The following is a description of a gene set: species: Homo sapiens A cell cycle process that results in the division of the cytoplasm of a cell after mitosis, resulting in the separation of the original cell into two daughter cells. Human Gene Set: GOBP_MITOTIC_CYTOKINESIS, and this is the list of marker genes: ANKRD53, ARF6, ZFYVE26, CHMP3, EXOC7, IQGAP2, CHMP1B, BBS4, INCENP, ARF1, SON, RAB11A, MYH14, MITD1, RHOC, KIF4A, RTKN, PLK1, SPTBN1, EXOC2, ECT2, ARL3, CHMP2B, MTMR3, ANK3, ESPL1, TRIM36, EXOC1, RHOB, IQGAP3, EFHC1, UNC119, EXOC8, KIF23, VPS4B, RHOA, CUL7, STMN1, PDCD6IP, CDCA8, USP8, CHMP4C, ROCK1, SPAST, EXOC6B, KLHDC8B, KIF4B, NUP62 (nucleoporin 62), CHMP4BP1, APC (APC regulator of WNT signaling pathway), LZTS2, KIF20B, CENPA, AURKB, JTB, CHMP1A, RAB11FIP3, ZFYVE19, MAP9, ANLN, CHMP2A, CHMP6, CHMP5 (charged multivesicular body protein 5), KIF20A, POLDIP2, IQGAP1, SEPTIN6, EXOC6, CEP55, CKAP2, SNX9, CFL1, RACGAP1, SNX33, BIRC5, ZNF365, DCDC1, SPART (spartin), NUSAP1, CHMP4B, RASA1, MTMR4, EXOC4, STAMBP, EXOC3, CHMP7, SNX18 (sorting nexin 18), VPS4A, MYH10, CIT, RAB35, CHMP4A, EXOC5, TTC19, WNK1, CNTROB, IST1, ROCK2 (Rho associated coiled-coil containing protein kinase 2)